The following is a description of a gene set: Removal of the transcription factor SAP1a member of the Ternary Complex Factor (TCF) group of transcription factors which in conjunction with Serum Response Factor (SRF) has been shown to have a profound effect on positive selection in the thymus. When another TCF Elk1 is knocked out in mice there is no effect on positive selection unless it is on a Sap1a KO background where the phenotype is very severe. We have stimulated isolated double positive T cells (DPs) with anti-CD3 to mimic positive selection and compared basal and stimulated transcription across the four genotypes to discover the downstream targets of Sap1a involved in positive selection. Human Gene Set: GSE21546_WT_VS_SAP1A_KO_AND_ELK1_KO_DP_THYMOCYTES_DN from publication Costello P, Nicolas R, Willoughby J, Wasylyk B, Nordheim A, Treisman R (PMID 20554967) Genes down-regulated in untreated double positive thymocytes: wildtype versus ELK1 and ELK4 knockout. species: Homo sapiens, and this is the list of marker genes: ESAM, PLCG1, CAMKK1, TAMALIN, NHLRC3, TJP2, ZNF266 (zinc finger protein 266), RNF149, MTMR12, RAB11FIP5, IDUA, SEMA3D, VNN1, ATP8B2, TTC3, CYP4V2, SLC12A7, AFF3, CERS4, ZNF608, PHC1, TMEM269, CDH5, GIMAP8 (GTPase, IMAP family member 8), PARD6G, MYO5C, HMG20A, MFHAS1 (NCBI Gene Id 9258), DCUN1D1, C11orf54, TCF7L2, TLE2, SASH1, FRY, RASAL2, IRF1, LAPTM4B, ST3GAL1, IL2RG, ADGRA2, PROCR, PAK6, CHRNB1, KANK2, TSC22D1, GDI1, RHBDF1, COBLL1, LRRC28, LRRCC1, TRIM68, HOXA9, ARHGAP29, ATP6V1G1, TEAD2, GIMAP5, SPRED3, APBB2, SLC12A2, TOR4A, ADGRL4, NFIA, PTPRK, ACOX1, HGF, ZNF623, MPL, TMCC1, UTRN, ARMCX1, CELF5, ZIC1, TSC1, TTC28 (NCBI Gene Id 23331), ANTXR2 (NCBI Gene Id 118429), IL17RE, MAP4, MAGEH1, ARHGEF7, GTPBP2, CYRIA, C1orf43, ANKRD50, ITIH5, HLF (NCBI Gene Id 3131), PHACTR4, PTGS1, CHEK2, AKAP7, PEAR1 (NCBI Gene Id 375033), RIGI, CXXC5, AMOT, PREX1, DDAH2, GPR4, SLCO2A1, ZRANB3, CCND2, SRGAP3, CDK19, RETREG1 (reticulophagy regulator 1), TBC1D1, ERG, RCBTB2, IFI44, PKD1, ARHGAP23, AGO1, CLN3, EXPH5, AXL, SYNE4, FSTL1, IGIP, MYLK, PLEKHA2, SOX18, PARD3B, MYOM1, CSAD, MRTFB, DOK2, CSGALNACT1, HMGA2, TP53INP1, TCF4, TRIM25 (tripartite motif containing 25), ARID4A, BACH2, ZFHX3, RPS6KA5, GIMAP1, FNBP1, SPOPL, VLDLR, ABCG1, FNBP1L, TNIK, HOXA5, PIANP, MECOM, CEP68, SH2D5, RNF213, PHTF2, TMEM154, CSNK1G3, MMP2, RETREG3, PPP2R5C, STIL, COL4A1, LRRC8C, CAND2, RBM47, RBM33, GCH1, FBXO5, NR2C1, H1-0, MAMDC2, TSPAN14, NIBAN2, DTX3 (NCBI Gene Id 196403), ZFP69, ZFAND6, MEG3, LUZP1, GIMAP7, ANKRD6, CSRNP1, ATP10D, GRAP, CASP12, LRRC4C, AGPAT4, FOXO3, PARP14, MDC1, GRAMD4, PRKD3, SIRT3, PDCD1LG2, GIMAP6, PHLPP1, CCL4, FCHSD2, ARHGAP30, SESN1, ZNF467, IRF6 (interferon regulatory factor 6), EPC1, SH3BP5, STXBP4, LSM14A, NRIP1, CREBRF, PITPNC1, GRAMD1B